The following is a description of a gene set: species: Homo sapiens Human Gene Set: chr6p11, and this is the list of marker genes: GAPDHP15, GUSBP4, RBBP4P4, PRIM2, LINC00680, ENSG00000225096, ENSG00000306225, MIR548U, POM121L14P, RAB23